The following is a description of a gene set: Reduction in the concentration of albumin in the blood. Human Gene Set: HP_HYPOALBUMINEMIA studied in species Homo sapiens Hypoalbuminemia, and this is the list of marker genes: ALB, SETX, B2M, XIAP, ARHGAP24, NLRC4, ATP7B, ANKFY1, DGUOK, AP1B1, TFAM, APTX, AP1S3, WDR4, TCF4, TNPO3, ALG1, NPHS2, SGPL1, ALG6, VPS33A, MAP2K1, SLC25A13, IL12A, APOL1, RNF31, EMP2, DSG1, DAAM2, MMEL1, ARHGDIA, PLVAP, BMPR1A (NCBI Gene Id 8035), ITGA3, DHCR7, MAGI2, TRMU, POLG2, IL36RN, TDP1 (NCBI Gene Id 55775), PAX2, MPI, PDSS2, MTTP, PTPRO, DGAT1, POU2AF1, NUP160, NUP37, GPR35, GAPVD1, INF2, COQ8B, CD2AP, FOXP3, NUP107, ACSL5, IRF8, CD55, ANLN, NUP93, WT1, EIF2AK3, SEMA4D, PTEN, MST1, UNC13D, ERCC4, MPV17, NUP205, ACTN4, TKFC, IARS1, TBC1D8B, STXBP2, LARS2, WDR73, PMM2, RNU7-1, TNFSF15, IRF5, FARSA, DGKE, ALG9, KRT5, SPIB, NUP133, PIK3R5, COL7A1, SYK, IFT56, IFNGR1, TRPC6, PLCE1, CCBE1, PET100, SLCO2A1, STX11, BRAF, MICOS13, COL4A3, ALG12, AHCY, SKIC3, KRT14, SCARB2, SH2D1A, FN1, PRF1, NPHS1, NRAS, SMAD4, CRB2, MYO1E, IL12RB1, FARSB, OSGEP, ALG8, MYO5B, SAR1B, PNKP, NUP85